Given this list of marker genes Gpr37l1 (NCBI Gene Id 98650), Gli2, Cend1, Slc6a4, Fgf2, Skor2, Igf1, Zfp423, Shh, Gli1, Lhx5, Smo, Egf, here is a description of the gene set: The process that modulates the frequency, rate or extent of granule cell precursor proliferation. species: Mus musculus Mouse Gene Set: GOBP_REGULATION_OF_CEREBELLAR_GRANULE_CELL_PRECURSOR_PROLIFERATION